Given this list of marker genes NCK1, JUN, NPHS2, MAPK9, ARRB2, PRKCI, PIK3CB, PLCG1, PIK3CD, PARD6A, KIRREL1, PIK3R3 (phosphoinositide-3-kinase regulatory subunit 3), PIK3R2, F2RL2, NPHS1 (NPHS1 adhesion molecule, nephrin), CD2AP, TRPC6, BAD, NCK2, PIK3CA, PRKCZ, MAPK10, MAPK8, AKT1, PIK3R1, TJP1, GRB2, FYN, MAP2K4, RAC1, WASL (WASP like actin nucleation promoting factor), here is a description of the gene set: Human Gene Set: PID_NEPHRIN_NEPH1_PATHWAY from publication Schaefer CF, Anthony K, Krupa S, Buchoff J, Day M, Hannay T, Buetow KH (PMID 18832364) species: Homo sapiens Nephrin/Neph1 signaling in the kidney podocyte